The following is a description of a gene set: studied in species Homo sapiens Genes predicted to be targets of miRBase v22 microRNA hsa-miR-149-5p in miRDB v6.0 with MirTarget v4 prediction scores > 80 (high confidence targets). from publication Chen Y, Wang X (PMID 31504780) Human Gene Set: MIR149_5P, and this is the list of marker genes: LMBR1L, TNKS, AAK1, KLHL3, LOX, WDR43, DLL1, APPL2, FOXC1, BRPF3, ELOA, SLC22A9, DAP, RSBN1L (round spermatid basic protein 1 like), GHR, NR4A3, VPS53, GAB2, ARHGAP21, TMEM234, STRA6, POLDIP2, SLC4A4, CCDC97, CACHD1, NTRK2, DDAH1, PHLDB1, FAM168B, IL6, AFF2, KCNN3, ISM2, APOL4, PHLPP2, CMTM3, EXOG, CNTNAP2, ZNF555, ATP2A2, FASLG, NAP1L1, JAKMIP2, RAP1A, EDAR, PEA15, THEM6, GIT1, SEMA4G, FKBP1B, MTF1, SRPK1, NFIX, BAIAP2L1, RNF2, ANP32A, DENND11, IQSEC2, TRABD2B, AEBP1, NRP2, TGFB2, AREL1, ZBTB2, HEG1, MRPL3, IGF2BP1, ARHGAP19, AVL9, BSN, ZFAND1, TBC1D16, BTRC, ISY1-RAB43, ATP10B, TMEM245, ADCY1, NDST1, STRADB, ZNF335 (NCBI Gene Id 63925), MARCKSL1, REPS2, KCNJ5, KCNJ12, RHOXF2, HMOX2, RAB43, UBFD1, IFFO2, SLCO3A1, ZMYM6, PDS5A, KIF2A, CACNA1C, RAB37, TNFRSF19, LRRC10, CNIH4, SNX18, SELENON, FRMD4A, RHOXF2B, VCF1, SORT1, MAGEB18, CDKL5, TBC1D2B, CZIB, GUCD1 (guanylyl cyclase domain containing 1), ELP5, CBX5, PARP8, ZNF74, NISCH, CNBD2, SMCO1, RGR, KLHL23, MIB1, PLA2R1, PURB, PCDH19, PDE1A, FBXL16, RSC1A1, RNF220, SNCAIP, SOCS6 (suppressor of cytokine signaling 6), NEUROD4, ASB4, NAPB, FAM177B, EXOC4, SRPX, BCL2L11, FRMD7, EPHB3 (NCBI Gene Id 2049), AMOTL2, AKT3, CBL, KRTAP4-1, STARD3, EXT1, USP10, GRIA3, CCT3, SHROOM2, ROR1, PIP4K2B, BRD10, RNF138, TCF12